Given this list of marker genes UBB, LGR6, FZD8, LGR5 (leucine rich repeat containing G protein-coupled receptor 5), LGR4, RPS27A, ZNRF3, RSPO1, RSPO3, LRP5, FZD6, WNT3A, RSPO2, FZD4, LRP6, RNF43 (NCBI Gene Id 54894), FZD5, UBA52, UBC, USP8 (ubiquitin specific peptidase 8), RSPO4, here is a description of the gene set: studied in species Homo sapiens Regulation of FZD by ubiquitination Human Gene Set: REACTOME_REGULATION_OF_FZD_BY_UBIQUITINATION